The following is a description of a gene set: Human Gene Set: GOBP_HEPARAN_SULFATE_PROTEOGLYCAN_BIOSYNTHETIC_PROCESS The chemical reactions and pathways resulting in the formation of heparan sulfate proteoglycans, which consist of a core protein linked to a heparan sulfate glycosaminoglycan. The heparan sulfate chain is composed of the repeating disaccharide unit beta-(1,4)-N-acetyl-D-glucosamine-alpha-(1,4)-hexuronic acid, the former being either sulfated or deacetylated on its amino group as well as sulfated on one of its hydroxyl groups, and the latter being e a mixture of sulfated and nonsulfated D-glucuronic and L-iduronic acids. Heparan sulfate chains are covalently linked to serine/threonine residues (O-linked) of the core protein via a tetrasaccharide linker sequence (xylose-galactose-galactose-glucuronate). studied in species Homo sapiens, and this is the list of marker genes: EXTL2, HS6ST2, NDST4, HS3ST5, XYLT1, UGDH, B3GALT6, EXTL1, HS6ST3, TCF7L2, B3GAT3, XYLT2, TM9SF2, HS3ST2, HS3ST3A1, EXT1, HS3ST1, HS6ST1 (NCBI Gene Id 9394), VANGL2, HS3ST4, EXT2, CTNNB1, NDST3, HS2ST1, SLC35D2, HS3ST3B1, EXTL3, DSE, CSGALNACT1, HS3ST6 (NCBI Gene Id 64711), NDST1, PXYLP1, GLCE, NDST2